The following is a description of a gene set: Human Gene Set: REACTOME_SULFUR_AMINO_ACID_METABOLISM Sulfur amino acid metabolism studied in species Homo sapiens, and this is the list of marker genes: MTRR, TXN2, BHMT2, ADO, FMO1, BHMT, SLC25A10, MAT1A, MPST, GOT2, CSAD, CDO1, AHCY, CBS, TSTD1, TST, ADI1, ETHE1, MTR, GADL1, SUOX, SQOR, APIP, MTAP, ENOPH1, GOT1, MRI1, CTH